The following is a description of a gene set: Genes containing one or more binding sites for (ZNF555) in their promoter regions (TSS -1000,+100 bp) as identified by GTRD version 20.06 ChIP-seq harmonization. Human Gene Set: ZNF555_TARGET_GENES from publication Yevshin I, Sharipov R, Kolmykov S, Kondrakhin Y, Kolpakov F (PMID 30445619) species: Homo sapiens, and this is the list of marker genes: ILDR1, ANGEL1, ADA, RPL36P2, RNU6-386P, ITGAL-AS1 (ITGAL antisense RNA 1), SPATS2L, PPIP5K2, KRT18P45, ACER3, LINC00581, LYN (LYN proto-oncogene, Src family tyrosine kinase), RNA5SP474, TTC1, EXOSC2, RNU1-101P, IL16, CWC25, NLE1, NANOGNB, ASS1P5, LINC02390, FCHO2, TMEM98, SH2B3, RND1, MB, PPP1R42, MORF4L1P5, BORCS6, NUCB1-AS1, CD160, JHY, PLA2G4C, ENSG00000244137, GLRX5P2, GAS8, RNU4-62P, TNFRSF10B, SLC22A11, TRPM6, LIPA, AURKB, CEACAM21, NCKAP1L, FES, H3P44, MTFMT, STX4, RN7SKP270, RORA, CYP1B1-AS1, DNAI4, ATP9B, RNU6-1340P, SPMIP10, CMKLR2-AS, RNU6-847P, POMT2, SSX7, SOX9-AS1, MIR3529, SDAD1P3, RRN3P1, RFC1, COPS5P1, SLC6A1, MIR764, GIT2, RNU6-85P, NAPSA, YAP1P1, HAPLN2, ZNF863P, EVA1C, ENSG00000265246, MIR3162, QSER1, PTPN2, CUL4AP1, BBLNP1, ACACA, PVT1, RNU6-612P, TRAV15, C6orf141, RB1CC1, NPAT, WNT8A, ENSG00000243004, ST7L, CDK4, LINC01235, TPM4P1, RLIG1P2, AGMAT, MED21, TPRXL, FMN2, TRIM15, MLST8, PPATP1, GLG1, IGSF21, JAZF1-AS1, GTF2I, TRIM55, TCEAL8P1, RNU6-916P, FRMD7 (FERM domain containing 7), SLFN12, PRAMEF29P, RN7SL93P, SNAP25, TNRC18, VOPP1, CROCCP3, AKAP9, TGFB1, NOL6, ANGPTL6, RPL32P27, MTND1P14, AP1S3, CDCA7P1, LIM2-AS1, ALDOA, RASA4EP, LINC01485, MIR3611, VPS39, CCDC65, COPS3, MTO1, ZNF675, RNU6-166P, LINC01641, PTK2B, UTP4, DHTKD1, SYCE2, FABP5P3, KAT8, FAM177A1P1, GALNTL5, RYR3, GDI2, CTNNA2, DUS2, RPL39P18, GXYLT2, MAP4K5, ZEB2P1, CFAP299, RNU6-1003P, MIX23, C1orf87, ARPC1A, SDC4, HNRNPMP2, PLA2G15, ABHD17A, ESPN, SNHG30, HEBP2, OR1X5P, SCN3B, FOXP1-AS1, SNORD81